Given this list of marker genes SLC39A8, STEAP2, MIR210, IFNG, LCN2, ISCU, here is a description of the gene set: Human Gene Set: GOBP_IRON_ION_IMPORT_ACROSS_PLASMA_MEMBRANE The directed movement of iron ions from outside of a cell, across the plasma membrane and into the cytosol. species: Homo sapiens